Given this list of marker genes GBP5, CASP1, IFI16, IL17A, JAK2, MIR181D, USP50, MIR488, AGER, AIM2, NLRP3, S1PR3 (sphingosine-1-phosphate receptor 3), MIR766, MIR144, INAVA, NOD1, ELF4, RIPK2, CARD16, EGR1, APP, IGF1, CCR7, SERPINB1, CARD18, P2RX7, ERRFI1, ARG2, MIR877, PYDC1, CD33, LILRA2, NOD2, AZU1, HMGB1, TLR6, CPTP, MIR98, LILRA5, RAD21, GSDMD, GHRL, TNF, TLR4, MIR195, FFAR1, MIR132, TLR8, ORM1, CCL19, MIR181A2 (microRNA 181a-2), PYCARD, TREM2, NLRP2, TYROBP, FOXP1 (forkhead box P1), HK1, CX3CR1, ISL1, LPL, CCL3, CASP8, CD36, STMP1, LILRB4, NLRP7, NLRC4, NLRP1, IFNG, MIR27B, CARD17P, TRIM16, MALT1, RELA, WNT5A, F2RL1, SPHK1, CARD8, ARRB2, NLRP2B, GHSR, HSPB1, TMEM106A, MIR101-1, GIT1, LGALS9, CX3CL1, ACP5, F2R, MEFV (MEFV innate immunity regulator, pyrin), SMAD3, CLEC7A, MIR204, ORM2, STAT3, SIRPA (NCBI Gene Id 96784), MIR920, PYDC2, PML, MYD88, APOA1, IL6, MIR206, NLRP12, MIR361, TNFAIP3, NAIP (NCBI Gene Id 82693), FFAR4, FZD5, ZC3H12A, MIR708, PANX1, GSTP1, here is a description of the gene set: Human Gene Set: GOBP_INTERLEUKIN_1_BETA_PRODUCTION studied in species Homo sapiens The appearance of interleukin-1 beta due to biosynthesis or secretion following a cellular stimulus, resulting in an increase in its intracellular or extracellular levels.